Given this list of marker genes Olfm2, Rnf10, Stxbp1, Fbxo2, Ap2b1, Ppp1r9b, Ap2s1, Picalm, Crkl, Nbea, Dnajc6, Ap2m1, Dgki, Fgf22, Scrib, Dgkb, Farp1, Tenm2, Cyth2, Cnksr2, Nptx2, Cyth1, Rims1, Olfm1, C1qc, Tiam1, Ctbp1, Sarm1, C1qa, Ctnna2, Snap91, Phb1, Magi2, Stxbp5, C1qb, Vwc2, Snap25, Akap9, here is a description of the gene set: species: Mus musculus The component of the synaptic membrane consisting of gene products and protein complexes that are loosely bound to one of its surfaces, but not integrated into the hydrophobic region. Mouse Gene Set: GOCC_EXTRINSIC_COMPONENT_OF_SYNAPTIC_MEMBRANE